Given this list of marker genes ALDH3A2, TGM5, AP1S1, SREBF1, PORCN, NDUFB11, ERCC5, KRT83, ITGB4, COL1A1, GCGR, SCN11A, MT-CO1, GJA8 (gap junction protein alpha 8), BLM, AIP, GNB2, XPNPEP2, MT-ND5, DBR1, CDKN1B, PLCG2, CTSB, FERMT1, KLK11, KDSR, KRT5, KRT10, ADAM17, GJB3, AQP5, PERP, HCCS, PDGFB (NCBI Gene Id 5155), TRPV3, IL17F, CLEC7A, ALOX12B, LRP1, IL17RA, KRT14, ERCC4, ERCC3, NSDHL, DSP, KCNQ2 (potassium voltage-gated channel subfamily Q member 2), MT-TH, NAXD, MT-ND1, SLURP1 (secreted LY6/PLAUR domain containing 1), DLL4, MT-CO3, GJA5, EGFR, COL7A1, KRT1, HLA-DQB1, PSMG2, ALOXE3, HLA-DRB1, LYN, ADGRE2, PGM3, USP8, COX7B, WNT10A, RNF168, SULT2B1, PIGL, IL36RN, SCN10A, GLUL, CTLA4, DST, LIG4, MT-TL1, TNFRSF1B, HPGD, RECQL4, SERPING1, PSMB8, IKBKG, XPA, MT-TW, XPC, LORICRIN, ANAPC1, IKZF1, MT-CO2, STAT3, C1QB, ITGA3, TGM1, SLC39A4 (NCBI Gene Id 55630), FECH, TNFRSF1A, ERCC2, PEPD, NOD2, BMS1, KIT, HLA-B, SCN9A, CD28, DDB2, MT-ND6, GJB4, CSTA, DSG4, RHOH (NCBI Gene Id 399), KRT2, STING1, MBTPS2, TRAF3IP2, NLRP3, DDR2, GJA1, MT-TS2, PLEC, MT-TQ, MEFV, MT-TF, ATP2C1, TRPM4, LIPN, MT-ND4, XRCC4, UBA2, ELOVL4, MVK, TREX1, IL17RC, here is a description of the gene set: Human Gene Set: HP_ERYTHEMA studied in species Homo sapiens Redness of the skin, caused by hyperemia of the capillaries in the lower layers of the skin. Erythema